Given this list of marker genes Pals1, Cldn5, Akr1b1, Marveld2, Mag, Sirt2, Jam3, Pten, Mpdz, Pard3, Ncmap, Cldn19, Mal, Anxa2, Prkci, Cdh1, Myoc, here is a description of the gene set: Regions within compact myelin in which the cytoplasmic faces of the enveloping myelin sheath are not tightly juxtaposed, and include cytoplasm from the cell responsible for making the myelin. Schmidt-Lanterman incisures occur in the compact myelin internode, while lateral loops are analogous structures found in the paranodal region adjacent to the nodes of Ranvier. studied in species Mus musculus Mouse Gene Set: GOCC_SCHMIDT_LANTERMAN_INCISURE